The following is a description of a gene set: Genes down-regulated in peripheral blood mononuclear cell (5 to 7)d vs 0d in adults (18-40) after exposure to APSV Wetvax, time point 5 to 7D Human Gene Set: SCHERER_PBMC_APSV_WETVAX_AGE_18_40YO_5_TO_7DY_DN from publication Scherer CA, Magness CL, Steiger KV, Poitinger ND, Caputo CM, Miner DG, Winokur PL, Klinzman D, McKee J, Pilar C, Ward PA, Gillham MH, Haulman NJ, Stapleton JT, Iadonato SP (PMID 17651872) species: Homo sapiens Gene expression in human peripheral blood mononuclear cells was systematically evaluated following smallpox and yellow fever vaccination, and naturally occurring upper respiratory infection (URI). All three infections were characterized by the induction of many interferon stimulated genes, as well as enhanced expression of genes involved in proteolysis and antigen presentation. Vaccinia infection was also characterized by a distinct expression signature composed of up-regulation of monocyte response genes, with repression of genes expressed by B and T-cells. In contrast, the yellow fever host response was characterized by a suppression of ribosomal and translation factors, distinguishing this infection from vaccinia and URI. No significant URI-specific signature was observed, perhaps reflecting greater heterogeneity in the study population and etiological agents. Taken together, these data suggest that specific host gene expression signatures may be identified that distinguish one or a small number of virus agents., and this is the list of marker genes: HYAL2, P2RX5, GRAP, CD2, FLNB (NCBI Gene Id 8413), FGFBP2, TARP, SNHG32, CD79B, ITPKB (inositol-trisphosphate 3-kinase B), OSER1, NAP1L4, SKAP1, SPIB, RPL12, SLC38A1 (solute carrier family 38 member 1), MS4A1, LLGL2, SPOCK2, IL24, CBLB